Given this list of marker genes SCYL1, TSPO (NCBI Gene Id 706), PEX12, G6PD, SRP68, FOXL2, PEX2, UXS1, SGCB, MESD, WNT6, AK3, ACTR10, MVB12A, DIS3L, POU2F1, MMP9, TAPBPL, TMEM165, RGS3, PEF1, GNE, CHPF2, CLU, RABL6, ALDH18A1, PDHB, CHI3L1, TMEM70, ATF6B, OXR1, MRPS2, FCGR2A, THAP7 (THAP domain containing 7), NXN, NFIC, DTD2, FEM1A, AKIRIN1, CD300C, TIMM17B, AP2B1, CYB561D2 (cytochrome b561 family member D2), BCKDK, ZDHHC12, DDX28, ARRDC5, GOSR2, MED22, ACER3, NSG1, EXOC6B, UFC1, TSEN2, SOAT2, CDO1, SMPD1, CAD, RAB38, SORBS3, CSF1R (NCBI Gene Id 8156), GSPT1, HDLBP, EIF2S2, DCUN1D4, ECSCR, MTFP1, CXCL10, TBL2, EFHC1, DUS1L, RPUSD3, ALDH3B1, CD300A, INTS14, HGSNAT, F2RL1, NID2 (NCBI Gene Id 95183), CERS2, CHST12, PDSS2, MRPL54, LCORL, IGLC7, SERF1A, EQTN, FAM241A, GDPD1, LRPAP1, NDUFAF7, PPP1R10, DCTN3, SND1, GOLGA3, SLC38A10, ARMC6, MOCOS, ACOD1, TBC1D8, ZNF260 (NCBI Gene Id 339324), GLCE, IMMT, TIMM8B, MRPL36, PON1, CCS, LRRN3, SPR, NUCB1, SMOX, ECD, CORO2B (coronin 2B), RIOK3, UBA3, AP4B1, SERPINB8, GBA2, TADA2A, PSMD1, JUN, PHAF1, NBEA, LTBP3, NEK6, ADAM8, ELP3, SLFN12, MBNL2, NEAT1, BRF2, MRFAP1L1, RHOB, ZNF473, RANBP2, NUP58, ANAPC13, SHQ1, TBC1D25, MRPS31, LEO1, RAB3D, SSR1, UBR3, TMEM263, TRMT61A, TMBIM1, CHRNB4, ACTR8, ACADVL (acyl-CoA dehydrogenase very long chain), VWA8, RWDD2A, LRMDA, ST14, CDK5RAP3, TSSC4, IL13RA1, IDE, TARBP2, SLC31A1, SLC11A1, ATP6AP2, SIGMAR1, BCL2L15, PFKM, THYN1 (NCBI Gene Id 29087), DNAJC1, ASCC3, C18orf21, HARBI1, ARCN1, ATPSCKMT, C1orf43, MKKS, SCFD2, VAT1, PON2, NDUFB7, PSMC2, ZSCAN25, IMPA2, TESC, LARS1, DNAAF2, POLDIP2, CMSS1, ARMCX2, PARL, TMEM9, RAB39B, TXNDC15, TBC1D7, SEPTIN8, TRAPPC6A, DNAJB11, VTCN1, VCPKMT (NCBI Gene Id 79609), CIAO3, RAB2A, PPT2, PDZD4, here is a description of the gene set: Th1 and Th2 cells arise from a common precursor cell in response to triggering through the TCR and cytokine receptors for IL-12 or IL-4. This leads to activation of complex signaling pathways, which are not known in detail. Disturbances in the balance between type 1 and type 2 responses can lead to certain immune-mediated diseases. Thus, it is important to understand how Th1 and Th2 cells are generated. To clarify the mechanisms as to how IL-12 and IL-4 induce Th1 and Th2 differentiation and how TGF-beta can inhibit this process, we have used oligonucleotide arrays to examine the early polarization of Th1 and Th2 cells in the presence and absence of TGF-beta after 0, 2, 6 and 48 hours of polarization. from publication Lund R, Aittokallio T, Nevalainen O, Lahesmaa R (PMID 14607935) Genes up-regulated in CD4 T cells: untreated (0h) versus activated by anti-CD3 and anti-CD28 and then stimulated by TGFB1 and IL4 (2h). studied in species Homo sapiens Human Gene Set: GSE2770_UNTREATED_VS_TGFB_AND_IL4_TREATED_ACT_CD4_TCELL_2H_UP